The following is a description of a gene set: Reactome Pathway: PI3K Cascade This event has been computationally inferred from an event that has been demonstrated in another species.<p>The inference is based on the homology mapping from PANTHER. Briefly, reactions for which all involved PhysicalEntities (in input, output and catalyst) have a mapped orthologue/paralogue (for complexes at least 75% of components must have a mapping) are inferred to the other species. part of: IRS-mediated signalling electronically inferred by orthology from the curated human pathway species: Mus musculus, and this is the list of marker genes: Pik3c3, Fgf4, Kl, Them4, Pdpk1, Fgf15, Tlr9, Klb, Grb2, Fgfr1, Fgf23, Fgf6, Flt3l, Fgf8 (fibroblast growth factor 8), Gab1, Fgf7, Fgf22 (NCBI Gene Id 67112), Fgf1, Fgf10, Fgf5, Fgf17, Pik3r2, Pik3cb, Irs2, Fgf20, Irs1, Fgf16, Fgf2, Frs2